Given this list of marker genes AVPR1A, SIPA1, PKD2, PIK3CA, AQP2, PLEC, here is a description of the gene set: studied in species Homo sapiens Human Gene Set: GOBP_CELLULAR_RESPONSE_TO_WATER_STIMULUS Any process that results in a change in state or activity of a cell (in terms of movement, secretion, enzyme production, gene expression, etc.) as a result of a stimulus reflecting the presence, absence, or concentration of water.